Given this list of marker genes KIFBP, MVK, SLC39A13, COG4, HECTD4, PHLDB1, SERPINF1, MEGF8, GHR, TMEM163, ESCO2, EXOSC1, TRMT5, CHST3, MED27, PPP1R21, CYB5A, ALPL, COL1A1, MESD, RMRP, CREB3L1, LRP5, DSE, B3GAT3, POLRMT, BMP1, SLC26A2, TGFBR2, KMT2D, GDF11, GNB2, PAX1, CSGALNACT1, RPS23, ROR2, CHST14, CHSY1, FBN1 (NCBI Gene Id 7470), INPPL1, WNT1, COL12A1, PPP1R15B, DVL1, FKBP14, ATP6V0A2, SMAD3, TGFBR1, TRMT10A, TELO2, NFIX, IKBKG, PRDM5, XYLT1, UNC45A, MBTPS2, CTCF, MSX2, SMAD2, WWOX, ZNF469, RYR3, KMT2A, PPIB, KDM1A, SON, CTSK, CANT1, TGFB2, PRMT7, ENPP1, B3GALT6, IFITM5, DVL3, COL5A1, PLOD1, FKBP10, CYB5R3, RNU4-2, SERPINH1, PGM1, TMEM38B, PUS3, SEC24D (NCBI Gene Id 9871), POLR3A, CA2, WNT5A (NCBI Gene Id 7474), FZD2, MAP3K7, WASF1, ABCC6 (NCBI Gene Id 5823), CRTAP, KDM6A, IGF2, SP7, PRKG2, BCL11A, C1R, TENT5A, COL3A1, COL1A2, NXN, B4GALT7, IPO8, TGFB3, ADAMTS2, P4HB, PYCR1, here is a description of the gene set: Blue sclerae studied in species Homo sapiens Human Gene Set: HP_BLUE_SCLERAE An abnormal bluish coloration of the sclera.